The following is a description of a gene set: An extrinsic apoptotic signaling pathway initiated by the binding of the ligand TRAIL (tumor necrosis factor-related apoptosis-inducing ligand) to a death receptor on the cell surface. Human Gene Set: GOBP_TRAIL_ACTIVATED_APOPTOTIC_SIGNALING_PATHWAY studied in species Homo sapiens, and this is the list of marker genes: TNFSF10, CASP8, ATF3, PARK7, TNFRSF10C, MIR222, SPI1, TNFRSF10A, ZDHHC3 (NCBI Gene Id 57245), TNFRSF10B, MIR221, FADD, TRADD